The following is a description of a gene set: studied in species Homo sapiens Human Gene Set: WP_LUNG_FIBROSIS Lung fibrosis, and this is the list of marker genes: IL13, CYSLTR2, FAM13A, IGF1, ATP11A, CMA1, PDGFA, MT2A, TNF (NCBI Gene Id 7124), EDN1, HGF, IL1B, SFTPA2, PDGFB, TGFA, PARN, TERT (telomerase reverse transcriptase), CALCA, CXCL8, IL6, CEBPB, CSF3 (NCBI Gene Id 170794), CCL4, CCN2, PLAU, CCL11, CCR2, SMAD7, STN1, CXCL2, CCL5, GREM1, FGF2, DSP, MMP2, IL4, RTEL1, BMP7, IL12B, TIMP1, IL5, SERPINA1, CCL2, EGF, SFTPC, ELN, FGF7, MECP2, SKIL (SKI like proto-oncogene), CSF2, MUC5B, TGFB1, FGF1, DPP9, PTX3, SFTPA1, CCL3, ELMOD2, HMOX1, NFE2L2, SPP1, CCR3, MMP9